Given this list of marker genes RTL1, SLC26A2, STX16, CA2, TMEM270, PLEKHM1, EIF2AK3, SETBP1, MC4R, CSF1R, DVL1, AP1S2, RFC2, LBR, GTF2I, SIK3, BAZ1B, TNFRSF11A, KARS1, HGSNAT, SNX10, HSPG2, AGXT, DHCR24, FLNA, HMGA2, ACP5, LPIN2, GTF2H5, AARS1, TBCE, RNF113A, AMER1, SLC34A2, FAM111A, CLCN7, GTF2IRD1, VCP, EBP, ERCC2, NGLY1, DLX3, RBL2, LIMK1, VPS37D (NCBI Gene Id 171020), CLIP2, MAP2K1, ERCC3, LEMD3, SRCAP, EIF4H, ERCC8, MAP3K7, ELN, GBA1 (NCBI Gene Id 82008), TRPS1, TNFRSF11B, MEG3, TONSL, ENPP1, SLC4A2, SOST, NAGLU, STX1A, MPLKIP, DMP1, FERMT3, METTL27, ANO5 (anoctamin 5), DNAJC30 (DnaJ heat shock protein family (Hsp40) member C30), KL, TBXAS1, GJA1, GNAS, PHEX, DLK1, SQSTM1, CARS1, TNFSF11, LMNA, SGSH, ERCC6 (NCBI Gene Id 282965), SLC39A14, ANKH, TCIRG1, WRN, AXIN1, SLC29A3, LRP4 (LDL receptor related protein 4), PTDSS1, OSTM1, TMEM53, PTH1R, RUNX2, NCF1, MITF, GTF2IRD2, LRRK1, LRP5, CTSK, HHAT, TRAPPC2, BUD23, TBL2, TARS1, FAM20C, BMP1, TGFB1, MTAP, NOTCH3, GTF2E2, FKBP6, here is a description of the gene set: Human Gene Set: HP_INCREASED_BONE_MINERAL_DENSITY Increased bone mineral density species: Homo sapiens An abnormal increase of bone mineral density, that is, of the amount of matter per cubic centimeter of bones which is often referred to as osteosclerosis. Osteosclerosis can be detected on radiological examination as an increased whiteness (density) of affected bones.